The following is a description of a gene set: Mouse Gene Set: MIR_3968 Genes predicted to be targets of miRBase v22 microRNA mmu_miR_3968 in miRDB v6.0 with MirTarget v4 prediction scores > 80 (high confidence targets). from publication Chen Y, Wang X (PMID 31504780) species: Mus musculus, and this is the list of marker genes: Rab31, Rcor3, 1700017N19Rik, Heyl, Zbtb24, Jmy, Elavl3 (ELAV like RNA binding protein 3), Spop, Slamf8, Derl2 (NCBI Gene Id 93680), Rasal2, Srpx, Lyn, Sftpa1, Gria4, Pla2g4c, Nbr1, Vapb, Nos1, Smc3, Stam2, Mier1, Crlf3, Sema4a, Sele, Rictor, Herc6, Rc3h1, Atf3, Spam1, Scn3a, Clec4d, Ankle2